Given this list of marker genes WNT7B, VIL1, TWF2 (twinfilin actin binding protein 2), EZR, WNT7A, PLS1, KEL, USH1C, XK, CNTN2, NEFL, CDHR5, CDHR2, here is a description of the gene set: studied in species Homo sapiens Human Gene Set: GOBP_REGULATION_OF_CELL_PROJECTION_SIZE A process that modulates the size of a cell projection.